Given this list of marker genes MCM2, PPARGC1A, MRTFA, OXCT1, CPE, HPCAL1, RASD1, ERBB3, CSN2, PPP1R15B, ZNF131, ST8SIA4, FOXA3, TSN, PSMB7, RPA3, SOX4, MVD, HMGN5, GATM, LUC7L, JTB, PDIA5, THOP1, MAT2A, SLC35E4, PRDX1, COIL, NPNT, PMPCB, H3C14, SLC5A1, BMP8B, H1-0, TGFB1I1, OGT, ABCB7, KGD4, LIFR, ACTR6, GRSF1, FCF1, HOMER3, ABCA4, TMED10 (NCBI Gene Id 10972), SNX10, SEMA4A, ASPSCR1, CDK2AP2, MRPL3, SLC25A10, EMC10, DPYSL3, VEGFB, NME4, TMED7, SELENOS, RGCC, LATS2, GRIA3, FMC1, C1D, ATP7A, TMEM71, FKBP1A, GOLIM4, KCNK7, IFRD1, MATR3, C5orf15, PEPD, MDM1, NDRG1, LGALS3, AHNAK, GJB2, VIPAS39, OSMR, NEUROD4, DMP1, TIMM8A, ZFP91, MSMO1, VPS37B, FOSB, NUDT4, MAPK12, CCR2, HCN1, CIP2A, CLDN7, PPP1R14B, TSFM, ID2, SQLE, DHX15, FBXO8, ATN1, TRPC5, XIST, HAUS6, TNFSF9, NEK6, RASA3, RNASEH2C, ABRACL, CLPX, RPL39, HIC1, GPATCH2, ZFHX4, PPP2R2A (NCBI Gene Id 5520), ENPP2, ONECUT1, PDK4, ARID1A, GTSE1, CBFA2T3, ACOT8, B3GALT1 (beta-1,3-galactosyltransferase 1), SNAPC2, ITGB7, TMPO, PIGA, UBE2H, PDCD2L, POLR2K, TSPAN3, MRPL39, PSMC6, CENPK, UBXN4, DDR1, HNRNPA3, NEUROG2, PTPRO, RBPJL, CDKN2B, EEA1, ITGA8, KLRD1, IL2RA, PSMA4, TRNT1, CACNA1H, MAFG, KCTD12, UCK2, HCFC1, UBA3 (ubiquitin like modifier activating enzyme 3), CXCL6, YBX3, FRMD6, ACR, AP3D1, SPTBN2, CASP1, KPNA1, VCP, GJC1, ALDH9A1, LAMP2, CHEK1, MIGA2, CRY1, TBCA, LDLR, GBP6, MTMR9, ANXA1, KRT25, NT5E, RPN1, ACADS (NCBI Gene Id 35), CAPRIN2, ULK2, UQCRC2, LANCL2, NR4A2, ERP29, GUSB, DPAGT1, IQGAP3, ATAD1 (ATPase family AAA domain containing 1), BNIP3L, COQ7, ODC1, USP15, IDI1, C6orf62, SLC31A1, ANTXR2, GLI3 (NCBI Gene Id 2737), ZNF638, HSF2, CAD (carbamoyl-phosphate synthetase 2, aspartate transcarbamylase, and dihydroorotase), CCDC86 (coiled-coil domain containing 86), MIS18A, SOCS2, FAM111A, here is a description of the gene set: The functional relationships and properties of different sub-types of dendritic cells (DC) remain largely undefined. We used a global gene profiling approach to determine gene expression patterns among murine splenic CD11c high DC subsets in an effort to better characterise these cells. Genes down-regulated in comparison of CD4 dendritic cells (DC) versus CD4- CD8- DCs. Human Gene Set: GSE339_CD4POS_VS_CD4CD8DN_DC_DN species: Homo sapiens from publication Edwards AD, Chaussabel D, Tomlinson S, Schulz O, Sher A, Reis e Sousa C (PMID 12816982)